The following is a description of a gene set: Human Gene Set: chr9q34 species: Homo sapiens, and this is the list of marker genes: PAEP, FPGS, ASB6, ENSG00000227619, SAPCD2, FIBCD1-AS1, MIR548AW, SETX, KCNT1, BARHL1, LRRC8A, DYNC2I2, COL5A1, ENSG00000284976, ARF4P1, PAXX, EXD3, DDX31, SNORD36C, NCLP1, AK8, TOR2A, PIERCE1, TMEM141, SOCS5P2, NAIF1, CCDC183, CCDC183-AS1, RNU5D-2P, QSOX2, ENG, TOR1B, SPACA9, ENSG00000227218 (novel transcript), C9orf78 (NCBI Gene Id 51759), OR4F8BP, MIR3154, UAP1L1, ENSG00000305600, RPL7A, EIF4A1P3 (eukaryotic translation initiation factor 4A1 pseudogene 3), TMSB4XP4, IL9RP1, PLPP7, PRRC2B, TSC1 (TSC complex subunit 1), MYMK, CACNA1B, ENSG00000236403 (novel transcript), DNLZ, ADAMTSL2, TTF1, GTF3C5, MRPL41 (mitochondrial ribosomal protein L41), PIP5KL1, SNHG7, FCN1, FNBP1, STPG3, TMEM210, CRAT, FAM78A, LINC02846 (NCBI Gene Id 105376323), TOR4A, ENSG00000286502, ENTPD8, CIMIP2A, RXRA, NTNG2, TRAF2, SARDH, SNORA17B, CELP, HMCN2, RN7SL328P, EEIG1, TOR1A, DBH, COL5A1-AS1, ENSG00000225032, PMPCA, ENSG00000300457 (novel transcript), LNCEGFL7OS, MIR4669, CLIC3, MIR126, LINC01451, SNORD36A, ENSG00000305683, EDF1, VTI1BP4, MIR6856, MAN1B1-DT, GRIN1, CCDC187, COQ4, NELFB, MIR199B, STKLD1, ZMYND19 (zinc finger MYND-type containing 19), DPM2, LINC02908, CAMSAP1-DT, POMT1, ENDOG, ENTR1, MIGA2, RNF224, RALGDS (ral guanine nucleotide dissociation stimulator), MIR4672, PAEPP1, ABO, NACC2, BRD3, CARD9, AK1, ST6GALNAC4, URM1, SLC25A25, ENSG00000289220, GOLGA2, ATP6V1G1P3, NUP188, ENSG00000228395, OBP2A, NIBAN2, ASS1, SLC34A3, SNORD62A, RPL21P81, PPP1R26, CERCAM, DOLPP1, QRFP, ODF2, SPTAN1, GPSM1, SURF6, ODF2-AS1, EXOSC2, ENSG00000309826, SNORA17A, LINC02975, FCN2, AJM1, TRUB2, SNORD62, PTPA, WDR5-DT, NOTCH1, PTGES2, SSNA1, DNM1, PTGES2-AS1, MIR3689B, RN7SL159P (NCBI Gene Id 106479279), ENSG00000288570, MIR602, REXO4 (REX4 homolog, 3'-5' exonuclease), RNU6-785P, SPOUT1, LINC01502, USP20, DBH-AS1, DPH7, ABCA2, FUBP3, LHX3, MIR3911, FIBCD1, STPG3-AS1, FAM163B, ST6GALNAC6, CFAP77, NOXA1, SEC16A, DIPK1B, LAMC3, SH2D3C, ANAPC2, SNORD36B, LCN8, AGPAT2, VAV2, CYSRT1, LCN12, SNAPC4, MAMDC4, MIR219A2, OLFM1, OBP2B, MIR3960, MIR219A2HG, ENSG00000275329 (NCBI Gene Id 107987142), ADAMTS13, MIR2861, SET, ARRDC1-AS1, LRRC26, LCN10, ENSG00000228877, TUBB4B, MIR3689E, LINC02247, LCN2, CEL, SLC2A6, PRRX2-AS1, MIR3689C, RNU7-171P, PHPT1, MIR3689F, UBAC1, NTMT1, HMGA1P4, MED22, MIR4292, C9orf163, SLC25A25-AS1, MIR4479, RNU6-881P (RNA, U6 small nuclear 881, pseudogene), LCN1P2, CIZ1, GFI1B, MIR219B, BBLN, DOLK, PTRH1, MRPS2, EHMT1, FUT7, ENSG00000236543, MED27, IER5L-AS1, RNA5SP296, DPP7, MIR7114, GPRACR, C8G, LCN15, PTGES, MIR6722, ENSG00000235138, MIR4674, SETP5, TUBBP5, RABL6, LCN6, LCN1P1, NPDC1, IER5L (immediate early response 5 like), PRRX2, NCS1, PPP1R26-AS1, SURF2, STXBP1, NSMF, SNORD62B, FAM157B, TMEM250, TMEM203, AIF1L, NUP214, SH3GLB2, CAMSAP1, EEF1A1P5, CFAP157, FBXW5, ENSG00000306759, PNPLA7, ZER1, ENTPD2, LCNL1, ARRDC1, PTGDS, GTF3C4, ENSG00000226706, RNU7-21P, TBC1D13, MIR6855, ABL1, LCN9, SOHLH1, KYAT1, GPR107, LINC02907 (NCBI Gene Id 157927), MIR6877, SNORD24, RN7SL560P, EGFL7, MAN1B1, C9orf50, LINC01503, SLC27A4, MIR3689A, ENSG00000203987, ZDHHC12 (NCBI Gene Id 84885), ZDHHC12-DT, RAPGEF1, UCK1, PKN3, RN7SL665P (RNA, 7SL, cytoplasmic 665, pseudogene), MIR3689D1, PRDM12, UBE2V1P4, SURF1, SURF4, NDOR1, SWI5, CDK9, MIR4673, PHYHD1, RNU6ATAC, LCN1, TTC16, PRRT1B, LINC02692, GBGT1, CACFD1, TPRN, GLT6D1, MIR3689D2, MIR3621, GLE1, BRD3OS, LINC00963, ENSG00000293104 (NCBI Gene Id 651337), DKFZP434A062, WDR5, RNF208, NALT1, NRARP, INPP5E